Given this list of marker genes CLIP1, PPME1 (NCBI Gene Id 51400), HAUS3 (HAUS augmin like complex subunit 3), RPA1, TERF2, HUS1, PRIM1, NCAPG2, CHMP2B, PPP2R5B, PPP2R2A, PPP2CB, DNA2, H3-3A, TUBA3D, MIS12, AKT1, PPP2R1A, NSL1, SHQ1, TICRR, TUBG1 (NCBI Gene Id 7283), CDK5RAP2, RUVBL1, DBF4, CHEK1 (NCBI Gene Id 1111), RPA3, SUN1, NUP214, CEP70, NSD2, CDKN2C, RAD21, LEMD3, SIRT2, CDKN2B, POLD3, PRDM9, CEP72, EMD (emerin, NCBI Gene Id 2010), USO1, RFC1, MAX, MIS18A, PSMD3, FBXO5, CDC25A, UBA52, NME7, PPP2R5A, POLR2K, MZT2A, ORC1, CNEP1R1, CENPA, CDC14A, CDCA5, EP300, NUP160, MAPK1 (NCBI Gene Id 5594), BORA, ESCO2, TYMS, PLK1, HERC2, LIN9, MSH5, TUBB3, CDC16, CEP164, PIF1, RMI1, RPS27A, KIF2A, CDCA8 (cell division cycle associated 8), POLR2D, PSMD2, HAUS2, LCMT1, POM121C, AHCTF1, SUN2, CCND3, MCM10, MCM2, NUP37, CCND1 (cyclin D1), CENPT, MZT1, H2BC26, TP53BP1, SMC1B, OFD1, CDKN1A, CENPF (centromere protein F), SEH1L, PSMD14, SPAST, MIS18BP1 (MIS18 binding protein 1), BARD1, SMC4, CDK4, DKC1, ADRM1, ANAPC1, TOP2A, PSMB4 (NCBI Gene Id 5692), RBX1, MCM5, NUP133, ZNF385A, MAPK14, CDK11B, PSMB5, DCTN3, RRM2, SRC, BABAM2, TEN1, NUP188 (nucleoporin 188), TUBA4A, FBXW11 (NCBI Gene Id 23291), RAB1A, CEP135, CENPO, NCAPD3, HAUS4, ATR, RPA4, MND1, PPP1CB, NUP54, POLE, MYC, CENPI, CENPW, FBXL18, TOP3A, CLASP1, CDK6 (NCBI Gene Id 1021), SYNE1, PRKCA, CENPS, OPTN, ORC5, NUP205, DAXX, TUBA1C, SGO2, CDKN1C, SPC25 (NCBI Gene Id 57405), PSMA4, TPR, GORASP1, RAD51, CDK2, TUBGCP3, ODF2, TUBA1B, MNAT1, SEM1, DYNLL2, POLR2B, NEK11, LMNA, RAN, H2BC11, TUBB1, RTEL1, PSMC3IP, DYNC1I2, TERT, NUP50, WAPL, TUBB8, COP1, SDCCAG8, PCM1, GTSE1 (G2 and S-phase expressed 1), INCENP, PPP1R12B, TERF1, TUBGCP6, PKMYT1, LBR, H2AJ, CDC25B, CENPH, CSNK1A1, HAUS5, NUP35 (NCBI Gene Id 129401), TFDP1, BUB1, CSNK2A1, GINS3, CLSPN, LIN52, POLR2J (RNA polymerase II subunit J), SMARCA5, CDC27, UBE2I, BIRC5, NUP153, NUP93, NUP155, H2AC20, PHLDA1, NUMA1, DYNC1H1, LYN, MAPK11, RBL1, MLH1, CDC26, UBE2V2, MAPRE1, PSMA5, POLR2C, CDK1, TAOK1, CABLES1, SYCP1, CENPL, H2BC15 (NCBI Gene Id 8341), PCNT, VRK1, E2F4, MAD2L1, NCAPH, CENPE, HJURP, MASTL, CCNA1, FBXL7, H2BC14, ANKLE2, FEN1, JAK2, E2F2, NUP62, RMI2, SET, BLZF1, HAUS8, SFI1, CEP192, CCNB2, PTTG1, HAUS7 (NCBI Gene Id 55559), CHMP3, CENPU, ZWINT, CENPC, CEP290 (NCBI Gene Id 9707), PRKAR2B, ZW10, PSMD7, CTC1, KNL1, AKT2, UBC, GINS4, IST1, H2BC13, CENPQ, BLM, RBBP4, SYCE2, NDC1, SMC3 (NCBI Gene Id 9126), FKBP6, NEDD1, PSMD12, POLR2E, H2BC1, E2F3, H2BC12, H2BC12L, NDE1, HAUS6, SKA2, LPIN1, ARPP19, POLR2G, TEX15, TP53, YWHAE, PSMA6, PPP2R1B, H2BC17, SSNA1, SYCE1, STAG1, VPS4A, UBE2N, CDC23, POLD4, H2AX, B9D2, PSMC1 (proteasome 26S subunit, ATPase 1), CC2D1B (coiled-coil and C2 domain containing 1B), TERF2IP, KMT5A, PSMC6, CDC45, CEP78, RCC1, CEP131, TUBAL3, TUBA8, YWHAQ, RFC4, PDS5B, SKP1, SMC1A, MAU2, H2AC4, CHMP7, NUP43, WEE1, ANAPC10, CDK7, CSNK1E, PSMD8, ALMS1, DYNLL1, RSF1, CLASP2, LIG1, FKBPL, CETN2, POLR2F, CCNE2, H2AC6, CHMP4C, POLE3, H2AC7, KNTC1, H2AC14, ACTR1A, YWHAB, SPO11, NEK9, TPX2, ESCO1, HSP90AB1, NPM1, H2BC9, CEP250, DIDO1, PPP2R5D, ANAPC7, HMMR, TUBB8B, TUBB2B, TOPBP1, RAB2A (NCBI Gene Id 5862), H2BC4 (H2B clustered histone 4), BTRC, TUBA3C, CEP43, NHP2, H2BC21, MCM3, UBE2S, SYCP3, RAE1, H3C15, CHMP2A, LIN37, TUBGCP4, PSMB6, BABAM1, PSMB7, PHF20, LIN54, DMC1, SPDL1, NUP58, RFC3, PPP2R2D, RNF168, UIMC1, MCM4, MYBL2, CSNK2B, CHMP6, MAPK3, PSMA1 (NCBI Gene Id 5682), ERCC6L, PLK4, EXO1, ANAPC4, CKAP5, MDC1, STN1, SFN, PCBP4, CEP57, DYNC1LI2, PSMA2, SYNE2, CEP63, CDKN2A, POLR2L, BUB1B (BUB1 mitotic checkpoint serine/threonine kinase B), FIRRM, BRCA2, MDM2, LPIN2, ATRX, RCC2, ATRIP, POM121, PSMC2, CENPK, MCPH1, ORC4, POLA2, PPP2CA, TUBB4A, DCTN1, CENPP, CHTF8 (NCBI Gene Id 54921), CEP152, NUP98, NCAPG, NUDC, MSH4, LPIN3, BUB3, H2AC18, ANAPC16, NUP88, TUBB4B, CDKN2D, PPP2R5E (protein phosphatase 2 regulatory subunit B'epsilon), CTDNEP1, H2AB1, CCNH, RBL2, POLR2I, SGO1, RAD9A, POLR2A, POLE2 (DNA polymerase epsilon 2, accessory subunit), EML4, RAD9B, PIAS4, PSMC5, CHTF18 (chromosome transmission fidelity factor 18), CDK11A, RAD1, KIF20A, RAB8A, SMC2, NEK2, POLR2H, H4C1, GOLGA2, PSMC3 (NCBI Gene Id 96121), PSMB1, RAD51C, MCM6, KAT5, CCNA2, TUBB2A, H2BC3, DYNC1I1, AURKA, PRKCB, PSMB2, CCNE1 (NCBI Gene Id 898), HDAC8, PHF8, PSMD11, FIGNL1, TUBGCP5, NDC80, BRCC3, ORC6, CDC20, SUMO1, SKP2, NOP10, AKT3, KIF2B, ZWILCH, MRE11, CUL1, CEP41, ABL1, H2AZ2, PLK3, HAUS1, CNTRL (centriolin), ANAPC2 (anaphase promoting complex subunit 2), TUBB6, HDAC1, PSMD6, RAD17, NCAPD2, MCM8, TUBB (tubulin beta class I), NIPBL, PMF1, PPP1CC, ATM, LEMD2, CDKN1B, CPAP, PSMD13, PPP2R3B, CHEK2, E2F1, GAR1, RAB1B, NDEL1, H2BC5, PPP1R12A, TMPO, CCNB1, CENPN, ENSA (NCBI Gene Id 51620), POLD1, POLE4, GORASP2, FZR1, RUVBL2, WRN, ANKRD28, E2F6, RPS27, RFC5, MLH3, CSNK2A2, POLA1, KIF18A, GMNN, MZT2B, RPA2, BRIP1, UBB, TK1, TUBA1A, AJUBA, LMNB1, TEX12, RFC2, STAG3, NUF2, NBN, AURKB, RHNO1, ANAPC15 (NCBI Gene Id 25906), PSMA3, POLD2, PPP6C, SPC24, TUBGCP2, PRIM2, CHMP4B, TUBA4B, ORC3, STAG2, ORC2, UBE2C, CKS1B, SYCP2, H3-4, TFDP2, GSK3B, FOXM1, MCM7, ANAPC11, NEK7, OIP5, RAD50 (RAD50 double strand break repair protein), ITGB3BP, E2F5, YWHAZ, PAFAH1B1, NINL, PCNA, NUP210, HSPA2, RANBP2, TINF2, ESPL1, RANGAP1, WRAP53, DHFR, KPNB1, NUP107, RBBP7, AKAP9, PSMA7, DSCC1, PPP2R5C (protein phosphatase 2 regulatory subunit B'gamma), DYRK1A, CCP110, CDC7, KIF2C (NCBI Gene Id 11004), TUBA3E, CEP76, HSP90AA1, GINS1, CDC6 (NCBI Gene Id 990), DCTN2, YWHAG, ABRAXAS1, MDM4, RB1, UBE2D1, CDC25C, KIF23, TUBG2, ACD, PSMB3, SKA1, NUP85, SEC13, GINS2, ANAPC5, DYNC1LI1, BANF1, UBE2E1, REC8, PTK6, XPO1, NCAPH2, POT1, PSMC4, RNF8 (ring finger protein 8), PRKACA, CDT1, CENPX, CENPM (NCBI Gene Id 79019), VRK2, CHMP4A, CCND2, BRCA1, H3C1, YWHAH, MAD1L1, OBI1, RBBP8, NEK6, PSMD1, DSN1, NUP42, PDS5A, PPP6R3, SYCE3, AAAS, CSNK1D, TNPO1, here is a description of the gene set: Reactome Pathway: Cell Cycle studied in species Homo sapiens The replication of the genome and the subsequent segregation of chromosomes into daughter cells are controlled by a series of events collectively known as the <b>cell cycle</b>. DNA replication is carried out during a discrete temporal period known as the S (synthesis)-phase, and chromosome segregation occurs during a massive reorganization to cellular architecture at mitosis. Two gap-phases separate these major cell cycle events: G1 between mitosis and S-phase, and G2 between S-phase and mitosis. In the development of the human body, cells can exit the cell cycle for a period and enter a quiescent state known as G0, or terminally differentiate into cells that will not divide again, but undergo morphological development to carry out the wide variety of specialized functions of individual tissues.<p>A family of protein serine/threonine kinases known as the cyclin-dependent kinases (CDKs) controls progression through the cell cycle. As the name suggests, the activity of the catalytic subunit is dependent on binding to a cyclin partner. The human genome encodes several cyclins and several CDKs, with their names largely derived from the order in which they were identified. The oscillation of cyclin abundance is one important mechanism by which these enzymes phosphorylate key substrates to promote events at the relevant time and place. Additional post-translational modifications and interactions with regulatory proteins ensure that CDK activity is precisely regulated, frequently confined to a narrow window of activity.<p>In addition, genome integrity in the cell cycle is maintained by the action of a number of signal transduction pathways, known as <b>cell cycle checkpoints</b>, which monitor the accuracy and completeness of DNA replication during S phase and the orderly chromosomal condensation, pairing and partition into daughter cells during mitosis.<p>Replication of telomeric DNA at the ends of human chromosomes and packaging of their centromeres into chromatin are two aspects of <b>chromosome maintenance</b> that are integral parts of the cell cycle.<p><b>Meiosis</b> is the specialized form of cell division that generates haploid gametes from diploid germ cells, associated with recombination (exchange of genetic material between chromosomal homologs).